The following is a description of a gene set: studied in species Homo sapiens The orderly movement of a cell from one site to another that will contribute to the progression of the heart over time, from its initial formation, to the mature organ. Human Gene Set: GOBP_CELL_MIGRATION_INVOLVED_IN_HEART_DEVELOPMENT, and this is the list of marker genes: FLRT3, BMP7, DCHS1, SNAI2, NDRG4, CDC42, EDNRA, BVES, HAND2, NOTCH1, SEMA3C, PITX2, FOLR1, ENG, TBX5, MESP1, TWIST1, EDN1, MIR1-1, PDGFRB, BMP4